Given this list of marker genes MYO1D, CST7, LAG3, RAB20, RGS13, GAA, PIM3, JAK2, TAS2R1, PTRH1, AGFG1, EGR1, MYO1E, SLC3A2, LRP10, PRKCA, CNTNAP4, GRIPAP1, F3, MACIR, GCNT1 (NCBI Gene Id 2650), RND2, SPRY1, ENTREP3, PRELID3A, S1PR3, APOC4, KRT86, TRPS1, CHRNB3, TOB2, ACE2, GRHL1, SLC38A1, CLCN6, EGR2, SYNPO, NSMF, ATP6V0B, VSX2, NGEF, CCR6, HYCC1, BEX1 (brain expressed X-linked 1), TNFSF14 (TNF superfamily member 14), PTGFR (prostaglandin F receptor), EEA1, OTUD7B, LEPROTL1, GM2A, CHPF, L3HYPDH, PTGES, SULT2B1, TPST2, GUCY1B1, PFKP, LCK, ZDHHC24 (zinc finger DHHC-type containing 24), RILPL2, IER2, IL2, IL15RA, SLC15A3, SLC66A2, PRXL2A (NCBI Gene Id 84293), LRRC8C, TBX21, TPD52, MAPKAPK3, HSPA5, MIR22HG, CMTM6, TNIP2, ARC, KRT71, RNH1, SYCE2, CYP2B6 (NCBI Gene Id 82059), ATP6V0C, AVPI1, SLC29A3, DTX1, FLVCR2 (NCBI Gene Id 55640), TMEM74B, ALCAM, LY75, ITGAV, TAGAP, PLEK, JAM2, EPHB3, IGF2R, TSSK6, SLC7A1, TRIO, DUSP4, GNG4, LRRC73, IL1R2, IL13RA1, HOMER2, VEGFB, SLC23A3, HLA-DRB1, AMZ2, CCNO (cyclin O), TUBB2A, SLC25A18, C15orf48, LIPG, UBASH3B, B4GALT5, TJP2, GMIP, XCL1, CHRNA3, VEZT, RENBP, TGFB1, PDXK, CHST11, HGS, CDC14B, SYNGR2, LAMP1, SPP1, BTG3, SH2D2A, GIT1, HLA-A, ST6GALNAC6 (ST6 N-acetylgalactosaminide alpha-2,6-sialyltransferase 6), SERPINB1, CSRNP1, PTGER4, AHI1, GFI1, TMEFF1 (NCBI Gene Id 8577), AHR, ATP6V0D1, RAB8B, BLK, FBXW11, CMTM2, FAM178B, MRGPRE, CPS1, PACSIN1, HLA-DRA (NCBI Gene Id 7930), MDFIC, NR4A3, STX3, CHKA, RBPJ, CASP4, LAT2, GABARAP, EMILIN2, SLC35B1, ROGDI, PPP1R15A, LNX2, DVL1, CENPV, PREX2, DEGS1, NAB2, LGI1, TIPARP, SAT1, SH3KBP1, TOX2, AP1M2, CMC2, PMP22, RBPMS2, NR4A2 (nuclear receptor subfamily 4 group A member 2), BLTP3A, NFATC1, NEO1, ATF3, RPS6KA2, CNIH1, DUSP14, CACNA1B, PLK3, CRYM, HIC1, CLN3 (NCBI Gene Id 1201), AVPR1B, SERPINB9, TNFRSF13C, NDFIP2, BRI3, PLAGL1, SRGN (NCBI Gene Id 5552), MALT1, TMEM51, ATN1, GPR65, here is a description of the gene set: CD4 T follicular helper (Tfh) cells provide the required signals to B cells for germinal center reactions that are necessary for longlived antibody responses. However, it remains unclear whether there are CD4+ memory T cells committed to the Tfh lineage after antigen clearance. Using adoptive transfer of antigen-specific memory CD4+ subpopulations (based on CXCR5 and Ly6c expression)in the LCMV infection model, we found that there are distinct memory CD4+ T cell populations with commitment to the Tfh and Th1 lineages. Our conclusions are based on gene expression profiles, epigenetic studies and phenotypic and functional analysis. The gene expression profiles of virus-specific CD4 T cell subets at effector and memory stages is presented here. species: Homo sapiens from publication Hale JS, Youngblood B, Latner DR, Mohammed AU, Ye L, Akondy RS, Wu T, Iyer SS, Ahmed R (PMID 23583644) Genes down-regulated in CD4 SMARTA effector T cells during acute infection of LCMV: Ly6c int CXCR5+ versus Ly6c low CXCR5-. Human Gene Set: GSE43863_LY6C_INT_CXCR5POS_VS_LY6C_LOW_CXCR5NEG_EFFECTOR_CD4_TCELL_DN